Given this list of marker genes Hc, Adrm1b, Serpinb9e, Cst13, Serpina1e, Serpini2 (serine (or cysteine) peptidase inhibitor, clade I, member 2), Mug2, Csn2, Stfa2l1, Spink4, Cd109, Smr2l, Naip1, Gbp5, Mapk9, Fetub (fetuin beta), Serpinh1, Gapdh-ps15 (glyceraldehyde-3-phosphate dehydrogenase, pseudogene 15), Anxa2, Ctsc, Serpina16, Csta1, Psmd14, Serpina12, Wfdc6b, Cst11, Serpinb6e, Vcp, Serpind1, Timp3, Wfdc2 (WAP four-disulfide core domain 2), Aph1a, Wdr48, Aim2, Serpinb9f, Gapdh, Serpina3f, Bcl10, Timm50, Casp8, Stfa2, Pbp2, Cstdc5, Ctsh, Spock1, Itih5, Nlrp3, Wfdc10 (NCBI Gene Id 634952), Serpinb3d, Cav1, Spink10, Cast, C3, Serpini1, Ahsg, Timp2, Tgfb1, Fn1, Ncstn, Serpinb9h, Kng2, Cst3, Tank, Spink13, Casp8ap2, Lxn, Serpinb9c, Cstdc6, Psme1, Spink2, Serpinb3c, Atp2a3, Thbs1, Ngp, Rock2, Serpina7, Smr2, Serpinb3b (serine (or cysteine) peptidase inhibitor, clade B (ovalbumin), member 3B), Tifab, Rack1, Itih3, Serpinb9d, Birc7, Serpinb2, Serpina3n, Psmf1, Itih1, Rarres1, Serpinb9g, Bin1, Acrbp, Psme4, Wdr20rt, Apaf1, Pzp (PZP, alpha-2-macroglobulin like), Nkx3-1, Serpina11, Pi16 (NCBI Gene Id 74116), Serpina3c, Serpine3, Sfrp2, Serpina5, Malt1, Cstdc1, Col28a1, Col7a1, Nlrc4, Psme3, Cst5, Gbp2b, Svbp, Wfdc8, Serpinf1, Cst12, Rps27l, Cst7, Spink12, Spint1, Wfdc15b, Serpina1a, Serpinb13, Wap, Nlrp1b, Bst2, Uchl5, Pcolce2, Serpinb12, Serpinb5, A2m, Dmwd, Psme2, Crim1 (NCBI Gene Id 50766), Serpinf2, Serpinb8, Tnfrsf10b, Pcolce, Aplp2, Serpina3i, Eppin, Cstdc3, Wfdc18, Slpi, Serpina3g, Serpinb3a, Tfpi2, Serpina3b, Furin, Pi15 (NCBI Gene Id 94227), Serpinb1b, Serpinb6c, Serpinb10, Spint2, Serpina3a, Gapdhrt2, Hspd1, Wfikkn1, Serpinb1c, Cst8, R3hdml, Spint3 (NCBI Gene Id 634878), Gm7298, Aph1c, Serpine2, Kng1, Serpina3k, Sorl1, Ctla2b, Clpx, Wdr20, Xiap, Ltf, Serpinb6d, Serpina3j, Pycard, Pebp1, Serpinb11, Wfdc12, App, Cstl1, Serpinb6b, Csta2, Aph1b, Pttg1, Wfdc21, Abca2, Col6a3, Timp1, Umodl1, Spink8, Gpc3, Serpina10, Birc5, Prnp, Cstb, Wfdc13, Park7, Cstdc4, Fbln1, Wfdc3, Wfdc6a, Birc6, Serpinb9b, Serpina1b, C4b, Gapdhrt, Serpinb6a, Itih4, Wfdc15a, Wfdc11 (WAP four-disulfide core domain 11), Ambp, A2ml1, Pcsk1n, Serpina1d, Mansc4, Spink5, Spink11, Timp4, Wfikkn2, Spink6, Spink7, Lgmn, Papln, Nlrp2, Spint4, Csta3, Snca, Bad, Arrb1, Prss22, Cflar, Elp2, Ngf, Serping1, Usp14, Psenen, Cst9, Vsir, Wfdc1, Wfdc16, Reck, Serpina1f (serine (or cysteine) peptidase inhibitor, clade A, member 1F), Serpina6, Tfpi, Spink1, Serpina3m, Serpinb7, Spock3, Mug1, Stfa1, Serpina1c, Wfdc17, Gbp2, Agt, Smr3a, Simc1, Serpinb9, Mmp25, Itih2, Renbp, Wfdc5, Stfa3, Serpinc1, Serpina9, Hrg, Crb2, Adrm1, Serpinb1a, Wfdc9, Nlrp1a, Serpine1, here is a description of the gene set: Binds to and modulates the activity of a peptidase, any enzyme that catalyzes the hydrolysis peptide bonds. Mouse Gene Set: GOMF_PEPTIDASE_REGULATOR_ACTIVITY studied in species Mus musculus